The following is a description of a gene set: Reactome Pathway: Disassembly of the destruction complex and recruitment of AXIN to the membrane species: Mus musculus electronically inferred by orthology from the curated human pathway part of: TCF dependent signaling in response to WNT This event has been computationally inferred from an event that has been demonstrated in another species.<p>The inference is based on the homology mapping from PANTHER. Briefly, reactions for which all involved PhysicalEntities (in input, output and catalyst) have a mapped orthologue/paralogue (for complexes at least 75% of components must have a mapping) are inferred to the other species., and this is the list of marker genes: Frat2, Ctnnb1, Dvl3, Fzd1, Fzd2, Dvl1, Frat1, Wnt8b, Wnt3a, Wnt8a, Dvl2, Wnt1, Ppp2r5b, Ppp2r5d, Amer1, Ppp2r1b, Cav1, Csnk1a1, Axin1, Lrp5, Ppp2r5a (protein phosphatase 2, regulatory subunit B', alpha)